Given this list of marker genes CANX, PRKG2, P4HA3, SEC11A, DNAJC10, OSTC, RPS27A, KPNA2, KPNB1, SPCS2, KPNA3, DPM1, KPNA4, KPNA5, RPN2, SEC11C, HYOU1, APOA1, MAGT1, XPO1, HSPA5, UBA52, SCAP, STT3B, TMEM258, KPNA1, DDOST, PRKG1, P4HB (NCBI Gene Id 94756), SPCS1, DNAJC3, P4HA1, P4HA2, OST4, TUSC3, SPCS3, PDIA3, SUMO1, RPN1, UBB, NMT1, UBC, ACOT2, IPO7, STT3A, UBE2I, KPNA7, CALR, DNAJB11, DAD1, DPM3, DPM2, here is a description of the gene set: Dengue virus (DENV) uses the host to fold and cleave its polyprotein, and mature the resulting fragments. The individual steps are highly conserved in all flaviviruses. The proteins prM, E, and NS1 are glycosylated with complex glycans or high-mannose sugars. Dengue proteins can undergo further modifications like phosphorylation, sumoylation, ubiquitination, myristoylation or hydroxyprolylation. C and NS5 also localize to the nucleus, and NS1 is secreted to extracellular space, where they interact with host factors. NS1, NS2A, NS2B, NS3, NS4A, NS4B, NS5 form the replication complex at foci near the ER membrane which later supports budding of virions into the ER lumen. part of: Dengue Virus Genome Translation and Replication Reactome Pathway: Maturation of DENV proteins studied in species Homo sapiens